The following is a description of a gene set: Impaired ability to stop or control alcohol use despite adverse social, occupational, or health consequences. Human Gene Set: HP_PROBLEMATIC_ALCOHOL_CONSUMPTION Problematic alcohol consumption species: Homo sapiens, and this is the list of marker genes: ADH1B, TBK1, TICAM1, PML, RARA, STAT3, HTT, TRAF3, ADH1C, UNC93B1, IRF2BP2, SGCE, TLR3, NPM1, LEMD3, NUMA1, BCOR, FIP1L1, NABP1, ZBTB16, SLC2A3, TAS2R16, TBL1XR1, STAT5B, PRKAR1A, GABRA2